The following is a description of a gene set: Among the multiple mechanisms that control the intensity and duration of macrophage activation, the development of a state of refractoriness to a second stimulation in cells treated with LPS has long been recognized. Release of inhibitory cytokines and alterations in intracellular signaling pathways may be involved in the development of LPS tolerance. Although a number of molecules have been implicated, a detailed picture of the molecular changes in LPS tolerance is still missing. We have used a genome-wide gene expression analysis approach to (i) define which fraction of LPS target genes are subject to tolerance induction and (ii) identify genes that are expressed at high levels in tolerant macrophages. Our data show that in LPS tolerant macrophages the vast majority of LPS-induced gene expression is abrogated. The extent of tolerance induction varies for individual genes, and a small subset appears to be excepted. Compared to other negative control mechanisms of macrophages, e.g. IL-10-induced deactivation, LPS-tolerance inhibits a much wider range of transcriptional targets. Some previously described negative regulators of TLR-signaling (e.g. IRAK-M) were confirmed as expressed at higher levels in LPS-tolerant macrophages. In addition, we discuss other potential players in LPS tolerance identified in this group of genes. Human Gene Set: GSE8621_UNSTIM_VS_LPS_PRIMED_AND_LPS_STIM_MACROPHAGE_UP studied in species Homo sapiens Genes up-regulated in naïve untreated macrophages versus tolerant macrophages stimulated by LPS. from publication Mages J, Dietrich H, Lang R (PMID 18086374), and this is the list of marker genes: VILL, SMIM6, PCLO, CELA1, CDCA8, PHF12, IER2, RSPH3, GTF2IRD1, SLC35C2, VLDLR, TBXAS1, S100A6, CD9, TMEM88, P2RX1, TLE6, RBX1, AARSD1, DFFA, WDR17, PGAP4, RADIL, TGM2, CUX2, CRLF2, MRPS27, CAVIN3, PPFIBP2, KHDRBS3, SERPINE2, KRT18, PAFAH2, ACSS2, MYCT1, ITGA6, FXYD5, CKS2, DGCR6, RACGAP1, PRRC2A, FLOT2 (flotillin 2), SDSL, RAB13, PRELID3A, DUSP28, SDHC, TRAF2, FAM110C, TSSC4, FADS2, PRKG1, MELK, G6PC3, PDLIM7, CORO1B, F11R (F11 receptor), NAPRT, PPME1, DENND2D, DLGAP5, ORMDL3, FAHD2A, GSTM5, JOSD2, TRPC4AP, RNF144B, ESAM, STAT5A, PAQR7, H3C4, FOSB, TCEAL1, TFR2, RYK, HSD3B7 (hydroxy-delta-5-steroid dehydrogenase, 3 beta- and steroid delta-isomerase 7), MC5R, FAM114A2, ARL2, KLF6, DLG3, IL11RA, CKAP2L, ADGRG1, KLF9, CDCA3, ZC3H7B, DHRS4, DIO2, VPS37B, ZFPL1, GKAP1, ZKSCAN5, COL4A2, GADD45A, SLC25A24, YRDC, LAIR1, DCAF4, TMEM97 (NCBI Gene Id 27346), CUEDC1, SORD, COX8A, TWSG1, TIMM10B, MIS18BP1 (NCBI Gene Id 55320), MEA1, TRIP6, H1-4, DEF8, TACSTD2, SLC18A2, SPINDOC, RNF5, CTNND1, SH3GL1, ATF4, BGN, ALDH1A1, AKAP8L, KIF18B, SGMS1, USB1, IRF6, GP9, PPP1R35, APP, CRIM1, ARMCX6, TNFAIP3, GLB1L2, NR1H2, COL16A1, C12orf75, CPA3, GJA1, TJP1, KNSTRN, TMEM237, NEIL3, GSTM3, THY1, RELA, TGFBI, SLC22A3, FAM98C, INF2, COQ10B, CC2D1B, ENG, SLC7A8, KYAT1, GATA1, ISG20, MPL, ADIPOR2, MAOA, CSGALNACT1, ARHGAP6, HNMT, SMIM11, MUC13, CYP4F22, ENDOV, NDC1, SAMD14, FLAD1, CCDC85B, TUBA8, JUNB (NCBI Gene Id 90482), GPSM2, MAGED2, TRAPPC3, NCLN, JUN, SUPT3H, SPNS2, APOE, DGKG, FKBP9, LCP2, ITGA2B, ARHGAP12, SDR39U1, DUSP4, TRADD, GFI1B, PLEKHF1, TPRKB, DUSP12, ALDOC, PHLDB2, EPB41L3, INAFM1, PDZK1IP1, PLK1, GBP2, ICA1, RILP